Given this list of marker genes SERPINF2, HLA-DQB1, STAT2, PSMB9, HLA-DRB1, SERPINE1, here is a description of the gene set: Abnormality of fibrinolysis Human Gene Set: HP_ABNORMALITY_OF_FIBRINOLYSIS species: Homo sapiens Clinical phenotype characterized by delayed bleeding accelerated break down of blood clot (fibrinolysis)